The following is a description of a gene set: studied in species Homo sapiens Human Gene Set: GOBP_POSITIVE_REGULATION_OF_DNA_BIOSYNTHETIC_PROCESS Any process that activates or increases the frequency, rate or extent of DNA biosynthetic process., and this is the list of marker genes: DKC1, CCT4, VEGFA, TNF, USP1, HTR2A, FGF2, FGFR4, CHTF18, POT1, POLG2, FBXO4, PTGES3, CHTF8, CCT7 (chaperonin containing TCP1 subunit 7), HNRNPD, HGF, CCT3, TCP1, SMOC2, RGCC (regulator of cell cycle), CCT6A, RFC5, PDGFRB, NOX4, PCNA, NAF1, CTNNB1, CCT8, HNRNPA1, CCNA2 (NCBI Gene Id 890), CCT2, WRAP53, PARN, ATR, ATM, TNKS2, DSCC1 (DNA replication and sister chromatid cohesion 1), TNKS, PRKD2, HSP90AA1, RFC2, PDGFB, RFC3, CCT5, RFC4